The following is a description of a gene set: studied in species Mus musculus Mouse Gene Set: REACTOME_SIGNALING_BY_NODAL Signaling by NODAL, and this is the list of marker genes: Smad4, Smad3, Smad2, Mapk3, Mapk1, Foxo3